The following is a description of a gene set: from publication Busslinger GA, Weusten BLA, Bogte A, Begthel H, Brosens LAA, Clevers H (PMID 33691112) studied in species Homo sapiens Human Gene Set: BUSSLINGER_GASTRIC_ISTHMUS_CELLS, and this is the list of marker genes: SEM1, SYTL2, CYP1B1, PSD3, PTMA, LMNA (lamin A/C), ETFB, CAST, SEC61G, SPINT2, PSMA4, BAZ1A, CYP3A5, PRKCD, LLGL2 (LLGL scribble cell polarity complex component 2), TPM4, TOP2A, RHOA, JPT1, TFF1, RAB2A, CTSE (NCBI Gene Id 1510), ETNK1 (ethanolamine kinase 1), MAL2, GOLGA4, SEC61A1, IL1RN, MRPL14, GALNT6, MGLL, CCNB1, LDLR, IER3, CD151, FAM177B, PAQR8, B4GALT1, RRBP1, GSTO1, FERMT1, ME1, BLVRB, CES2, TUBB4B, ITGB4, VCP, PERP, KLF3, FMN1, RAB11FIP1, PLLP, NCL, FOXA2, MARCKS, CAPN5, MGST2, TUBA1C, SLC44A2, SPINK1, LARP1, GFUS, PHLDA2, YWHAZ, HDGF, ATP5IF1, HMGB2, ANXA2, IBTK, KLF2, ASAP2, CMBL, CAPN8, MICU1, TXNRD1 (thioredoxin reductase 1), ALDH3A2, MYL6, TMED9, LINC01133, SNRPD1, WASF2, GNA11, MANF, CBR1, SMPD3 (sphingomyelin phosphodiesterase 3), CALR, ANO1, NANS, MAPK3, KRT8, ARHGAP21, BACE2, DDX21, LRRFIP1, TAGLN2, PTTG1, CLMN, PTTG1IP, SFN, CKAP4, CENPV, NDUFS6, LAMA3, RAN, TK1, CAPNS1, BHLHE40, SH3RF1, SDC4 (NCBI Gene Id 6385), ATP8B1, RPS8, NHSL3, GALE, NQO1, HDLBP, CIST1, NR2F6, REG4 (regenerating family member 4), TUBB, AKR1B10, KLF5, KHSRP, H4C3, DBI, RBM25 (NCBI Gene Id 58517), SLC7A8, CRELD2, PKP3, ADH1C, SLC39A11, KRT19, TUBA1B, PLXNA2, FABP5 (fatty acid binding protein 5), NUCKS1, SERPINB5, SERPINB1, ADD3, SEC63 (SEC63 homolog, protein translocation regulator), AHNAK, TSPAN15, KCNE3, EZR, NCOR1, AP2B1, MVP, ATP2A3, SEMA3B, HES1, CYP51A1, GMDS, DYNLL1, RALBP1, RPL36AL, ARF5, PSMD7, MYO1A (myosin IA), CKS2, S100P, RBM3, GIPC1, NKX6-2, RAB27B, TACC3, CYP2S1, ANXA10, CYC1, SYNGR2, LMO7, FXYD3, REP15, SGSM3, FLNB, FER1L6, HNRNPAB, GNB2, RPN1 (NCBI Gene Id 6184), KLF4, LFNG, LASP1, ITPR3, IL1R2, SERBP1, SF3B5, LIMA1, TMPRSS4, ALDH2 (NCBI Gene Id 217), RPS24, PRDX1, HMGCS1, HSP90B1, DHCR24, H2AZ1 (H2A.Z variant histone 1), HSPB1, CALM3, CAPZB, TRNP1, HYOU1, CORO2A, TCEAL9 (transcription elongation factor A like 9), YWHAB, SRSF1, PTPRF, MLPH, DST (dystonin), TSPAN3, LMO4, PTBP1 (polypyrimidine tract binding protein 1), TPX2, ZBTB7A, EDEM3 (NCBI Gene Id 87240), ADAM15, HSP90AA1, GARS1, COX8A, MYO5C, RASSF6, MISP, ESRP1, GPX2, PABPC1, YWHAH, PLEC, SNRPB, EIF3A, VASP, NIBAN2, MYOF, TKT, VPS35 (VPS35 retromer complex component), KIF1C, TACSTD2, GADD45A, KIF5B, VILL, MKI67, BCAS1, CDC42EP5, INF2, NOP56, CYP2C18, HSPD1, UBE2C, JUP, TSPO (NCBI Gene Id 706), ATP1A1, KDELR2, LARP1B, TM9SF3, DDX18, AGR2, PLA2G10, PDIA4, HMGB1, ALDH3A1, ENSA, CAPG, TMEM54, CENPF, PYCR1, EFNB2, CCT5, S100A10 (NCBI Gene Id 6281), HSPH1, FOXQ1, AUP1, ASPM, DHFR, FCGBP, GNL3, PTGES3, ARL6IP1, GSN, OSBPL7, FBLIM1, MESD, TRIM2, CTTN, MACROH2A1, GAPDH, SLC9A1, TPM3, PPARG, MYH14, TIMP1, GKN2, TSPAN1, KDELR3, SMC4, EIF3J, SDF2L1, AP1M2, HNRNPA2B1, CHCHD2, ACTN4, LMAN2, ITGB1, EIF4E2, TST, ACTR2, TFCP2L1, SERF2, PSMA7, FKBP2, DNM2, PSMD11, RBM47, LGALS3, GSTP1, CREB3L1, EIF5B, CD63, TSPAN8, NET1, CSTB, TES, RNU4ATAC (RNA, U4atac small nuclear), ACIN1, CDC37, S100A14, CRIP1, ARPC1A, ITGA6, CLIC1, PLEKHA6, TMSB10, PRC1, MCU, NFE2L2, PDLIM1, PPM1G, SPINK5, TOP1, LPCAT4, PHACTR2, CALM2, MRPS35, MYO10, S100A16, PFN1, P4HB, ARPC2, PEBP1, ELF3, SRRM1, KDELR1, ARHGDIA, ZBTB7C, U2AF1, STMN1, HSP90AB1, TMED2, CDH1, EPS8L3, CLTB, LAD1, S100A6, SULT1C2, PPDPF, TLCD2, EIF2S2, ARF1, AKR1C3, MYDGF, DNAJB11, PPIA, PLP2, SRSF3, H2AJ, EFHD2 (NCBI Gene Id 79453, EF-hand domain family member D2), NMU (NCBI Gene Id 10874), PLEK2, CDS1, DSP, LGALS4, CTNNA1, SLK, TLN2, EBP, MIDN, SNRPF, RAC1, NFIC, PALLD, YBX1, COX6B1, HPGD, FAM120A, TESC, AKAP1, BCAP31, CANX, SLC16A1, EI24, HNRNPF, CCDC25, TTC39A, MLEC, TXN, TMSB4X, VSIG1, MGST3, HNRNPM, RAB3D, VMP1, AGR3, TPM1, CCND1, RETSAT, TCERG1, CFL1, POMP, SPTBN1, SCD, TALDO1, CYP4F12 (NCBI Gene Id 66002), PDIA6, CENPE, ID1, SDC1, TENT5A, HSPA5, CLDN18, EPCAM, ABCC3, NUSAP1, TCF7L2, PPFIBP1, MUC1 (mucin 1, cell surface associated), SMIM14, MUCL3, PRPF38B, CAP1, SLTM, SNRPG, EIF6, RASEF, LAMB3, FHL2, SLC44A1, UGDH, RPN2, FASN, RPL35 (NCBI Gene Id 92393), ENO1, ACTG1, SYK, ABLIM1, MIA3, MTDH, EIF4G1, MVD, KRT18, CA2 (NCBI Gene Id 760), S100A11, ELOVL6, ATP5ME, FBP1, USH1C